Given this list of marker genes TACC3, DHX30, PUS7, FASTKD1, CALU, UBE2I, CCT3, TNIP3, EXOSC2, KIF3A, MREG, CFLAR, HSPA1A (heat shock protein family A (Hsp70) member 1A), MRE11, IDH2, MYB, ETF1, LRRC59, NHP2, RFC5, MED22, UGGT1, MCM4, RAMP1, POLD3, DRAM1, GPX1, HPGDS, CD9, TNF (NCBI Gene Id 7124, tumor necrosis factor), MCAM, CASP7, MED20, BCKDK, TMPO, ARHGAP19, IDE, GLA, C1QBP, SFT2D2, SLC35G2, ITGAE, FOXM1, NCF4, EIF3B, BID (BH3 interacting domain death agonist, NCBI Gene Id 637), MRPL17 (NCBI Gene Id 64996), POLR3K, NPRL3, WARS1, NCAPD3, FANCL, MRPS14, MUS81, EXO1, PSME2, GORASP2, CTSH, NDUFA7, NDUFB3, GALE, PDXK, APLP2, RAB13, CCT2, RPA3, THY1, KNTC1, TBL2 (NCBI Gene Id 27203), PTBP1, GSTA4, P2RX5, DHCR24, SUPT16H, HDLBP, TNPO1 (transportin 1), VCP, CD74, NDUFAF1, GMPPB, SLIRP, MAD2L1, HTRA2, DPP3, SEC14L1, POLD2, JCHAIN, DDX49, MKI67, MYL6B, SPDL1, TMEM176B, TWNK, CCNE1, GTPBP4, LAPTM4B, PPAT, GMPS, CCT5, AGGF1, HSD17B10, GLRX2, AGO2, COASY, TRIB1, DTL, ST7, BASP1, SLC35F2, MAFB, RBPJ, POLQ, SMCO4, MRC1, SEC23B, TRAF1, TMT1A, PPM1D, PXMP4, PSMD1, MT1HL1, RCC1L (NCBI Gene Id 94293, RCC1 like), RBM28, RAD54L, TNFRSF21, RDX, MAPK1 (NCBI Gene Id 5594), BLM, MCAT, MRPS12 (NCBI Gene Id 6183), PSMD8 (proteasome 26S subunit, non-ATPase 8), TFCP2, PWP2, ATP5MC1, DDB2, CCDC47, TAGLN2, ARPC5L, ALOX5AP, GABPB1, ICMT, PFDN2, PSMD14, TMEM53, PLPP3, EPRS1, BLVRA (NCBI Gene Id 644), IMP4, HLA-DRB1, SNRPD3, RAB8B, LSM4, KEAP1, SPINT2, NT5DC2, ODF2, NCAPH2, MRPL11, ARL3, HSPD1, MELK, TUBB4B, RMI1, RAD50, SMC2, BCL2L1, ESPL1, AGPAT5, KDELR2, IDH1, SRP54, CDC7 (NCBI Gene Id 8317), PREB, AHSA1, H2AX, GLB1, GCLM, CSF2RB, CCT7, SNU13, TMEM165, COPS7A, MRPS28, FAM136A, EMC8, KIF15, SRI, CASP3, MTHFD1, CDC45, NAA10, DHX16, FUCA1, TFB1M, IMMT, EBI3, TIMM8B (NCBI Gene Id 91900), TMED5, CENPN, PSMA5, here is a description of the gene set: Human Gene Set: GSE24634_NAIVE_CD4_TCELL_VS_DAY3_IL4_CONV_TREG_DN CD25+ regulatory T cells develop in the thymus (nTregs), but may also be generated in the periphery upon stimulation of naive CD4 T cells under appropriate conditions (iTregs). The mechanisms that regulate the generation of peripheral iTregs are largely unknown. We used microarrays to gain insights into the molecular program of extrathymic Treg development. from publication Prots I, Skapenko A, Lipsky PE, Schulze-Koops H (PMID 21347372) Genes down-regulated in comparison of naive T cells at day 0 versus CD25+ regulatory T cell (Treg) treated with IL4 at day 3. species: Homo sapiens